The following is a description of a gene set: species: Homo sapiens Human Gene Set: GSE42724_NAIVE_BCELL_VS_PLASMABLAST_DN The recent discovery of the human B1 cells, identified by the expression of CD20, CD27 and CD43 in absence of expression of CD70 and CD69 has been subject of debate. Some studies have raised the possibility that these cells are B cells differentiating towards the plasmablast and plasma cell stage rather than being the human counterpart of murine B1 cells. No further in depth studies have been performed. Therefore, a functional comparison was made between, the proposed B1 cells and plasmablasts. We observed that for several functional characteristics (distribution of isotypes of spontaneously producted antibodies, production of antigen-specific antibodies after vaccination with both T-cell dependent as well as T-cell independent antigen, the proposed B1 cells behaved similar to plasmablasts. In addition, we were able to differentiate the proposed B1 cells in vitro, indicating that they are not from a distinct lineage as the murine B1 cells. Gene expression analysis revealed that these cells cluster between memory B cells and plasmablasts, contradicting them being the genuine human counterpart of murine B1 cells, rather revealing a preplasmablast phenotype. Genes down-regulated in B lymphocytes: naïve versus plasmablasts. from publication Covens K, Verbinnen B, Geukens N, Meyts I, Schuit F, Van Lommel L, Jacquemin M, Bossuyt X (PMID 23613519), and this is the list of marker genes: TCEA1, GNPDA1, MPPE1, AP3S1, NCAPG2, HLA-DMA (NCBI Gene Id 3108), PDE3B, PAQR8, ENTREP1, PLA2G4A, F13A1 (NCBI Gene Id 2162), ZNF844, MORN2, FUCA1, IRAG2, TGFBR2, SLC46A3, CNOT7, C17orf100, ZNF641, DUSP23, TRIQK, CAND2, CCNY, UBE2E2, ZNF441, ASPHD2, MEF2C (NCBI Gene Id 4208), SYNE3, IL1R2, MRTFB, CMTM8 (NCBI Gene Id 152189), RCBTB2 (RCC1 and BTB domain containing protein 2), VCPIP1, COG5, POMGNT2, BBS9 (NCBI Gene Id 27241), AP1S2, HRH1, MCU, MBP, LRRC8C, ZBTB4, HACD4, CERS2, APBA1, NFATC3, DUSP13B, ZNF555, PITHD1, CELF6, NRGN (neurogranin), DENND4C, ATPAF1, CDCA7L, RGS18, ARHGEF6, EFCAB10, GPR146 (G protein-coupled receptor 146), RAB7A, GRAMD4, PDP1, ZCCHC24, EIF4E3, AATK, MED20, PWWP2B, ERP27, RTN3, CSK, ZNF571, GPR34, CCPG1, PBX3, CENPN, PER3, LST1, TACC1, DHX57, ADORA2B, SENCR, LRRC37B, ARHGAP15, CDK4, HADH, HLA-DMB, SLC2A8, CD1A, DIAPH1, SOCS7, C1orf162, LPAR6, STC1, ANKH (ANKH inorganic pyrophosphate transport regulator), CNRIP1, RNF130 (NCBI Gene Id 55819), TM6SF1, ADORA3 (adenosine A3 receptor), ASRGL1, DPEP2, KLF17P1, WWOX, ATP2B1, TCFL5, HHEX, PARVG, NCF2, SLC37A2, DCUN1D4, ZKSCAN4, GRHPR, KCTD7, RHBDF1, RHOBTB1, CD33 (NCBI Gene Id 945), MAN2A2 (mannosidase alpha class 2A member 2), FIRRM, TPM1, NUDT1, CHPT1, TET3, ZNF738, EMB, ZNF362, NAGPA, DUS2, IL16, MYO18A, KIF13A (NCBI Gene Id 63971), OTULINL, ING2 (inhibitor of growth family member 2), TNFSF12, NAGK, CCDC14, ATP6V0E2 (NCBI Gene Id 155066), TLR4, DOK2, POGK, CPM, MAP4K1, TMEM168, SNX18, ADCY7, TSPAN32, P2RY12, FCGRT, CAPN2, NCAPH, IMPA2, NDRG3, MYO1D, CXCR2, C11orf21, ANKRD50, CHEK2, SAMD13, SLC25A48, GDPD1, ATM, ZFP36L2, TMEM86A, ZNF569, MTCL1, CTDSPL, MCOLN1, DHRS9, PAK1, RTL6, ATOSA, SNX24, ZBED3, SHB, PVT1, DNMT1, CCDC34, TRIM36, CCSAP, CPNE8, PAGR1, P2RY14, SEPTIN9, PRKACB, APBB1IP, LY86-AS1, PAQR5, IFT172, PINK1, TMEM250, PLXDC2, SLC35F6, ARL4C, FEZ2, GAS7, HSPBAP1, MLEC, STARD9, DCBLD1, ASB1